Given this list of marker genes GSTA4, BGN, CDC25B, SPTAN1, GSTO1, CDKN1B, WNT5A, IL6ST, BRCA1, DAPK1, TIMP1, UMPS, TANK, ERBB2, PDGFRB, CASP1, GTF2H5, EGR3, IGFBP6, BHMT, SMAD1, IDI1, ABL1, MAP3K1, SMAD4, ERCC1, RHOB, IFNG, CCNE1, BAX, CAV1, HMGCR, BID, DVL3, PLAT (NCBI Gene Id 5327), FGF11 (fibroblast growth factor 11), FGF2, IGFBP7, TLR3, TP53, TNFRSF10A, IL1R1, BTG3, GJA1, IL6, APAF1, FGFR1, DPYD, POLG, IGF2R, SHC1, MYD88, CXCL8, IGFBP3, SMAD7, MGMT, TIMP2, CFLAR, IFNA10, TIMP3, IFNGR1, MARS1, PRKCA, IGFBP4, CDKN1A, FGF7, FANCG, GPX3, SMAD5, TYMS, IGFBP5, PDGFRA, GSTM5, DUT, IRF6, PRKACB, SHC3, GADD45A, GSTM1, MMP2, SKIL, IL1A, MAT2B, CASP6, DCTD, POLR2E, PLAUR, TNFRSF10B, DCN, IGFBP2 (NCBI Gene Id 3485), RAD23B, PTEN, PDGFD, GTF2H4, SC5D, HGF, GSTP1, EREG, BMP2, BTG2, BORCS8, JUN, FZD1, LUM, CASP7, PERP (p53 apoptosis effector related to PMP22), HSPB1, CREBBP, RNASEL, CASP3 (NCBI Gene Id 836), LITAF, FAS, FDFT1, TGFB2, YWHAQ, POLB, WEE1, MTR, here is a description of the gene set: studied in species Homo sapiens Human Gene Set: KOKKINAKIS_METHIONINE_DEPRIVATION_96HR_UP from publication Kokkinakis DM, Brickner AG, Kirkwood JM, Liu X, Goldwasser JE, Kastrama A, Sander C, Bocangel D, Chada S (PMID 16908595) Genes up-regulated in MEWO cells (melanoma) after 96 h of methionine deprivation. Methionine deprivation stress (MDS) eliminates mitotic activity in melanoma cells regardless of stage, grade, or TP53 status, whereas it has a negligible effect on normal skin fibroblasts. In most cases, apoptosis accounts for the elimination of up to 90% of tumor cells from the culture within 72 hours after MDS, leaving a scattered population of multinucleated resistant cells. Loss of mitosis in tumor cells is associated with marked reduction of cyclin-dependent kinase (CDK) 1 transcription and/or loss of its active form (CDK1-P-Thr(161)), which is coincident with up-regulation of CDKN1A, CDKN1B, and CDKN1C (p21, p27, and p57). Expression of the proapoptotic LITAF, IFNGR, EREG, TNFSF/TNFRSF10 and TNFRSF12, FAS, and RNASEL is primarily up-regulated/induced in cells destined to undergo apoptosis. Loss of Aurora kinase B and BIRC5, which are required for histone H3 phosphorylation, is associated with the accumulation of surviving multinucleated cells. Nevertheless, noncycling survivors of MDS are sensitized to temozolomide, carmustin, and cisplatin to a much greater extent than normal skin fibroblasts possibly because of the suppression of MGMT/TOP1/POLB, MGMT/RAD52/RAD54, and cMET/RADD52, respectively. Sensitivity to these and additional genotoxic agents and radiation may also be acquired due to loss of cMET/OGG1, reduced glutathione reductase levels, and a G(2)-phase block that is a crucial step in the damage response associated with enhancement of drug toxicity. Although the genes controlling mitotic arrest and/or apoptosis in response to low extracellular methionine levels are unknown, it is likely that such control is exerted via the induction/up-regulation of tumor suppressors/growth inhibitor genes, such as TGFB, PTEN, GAS1, EGR3, BTG3, MDA7, and the proteoglycans (LUM, BGN, and DCN), as well as the down-regulation/loss of function of prosurvival genes, such as NFkappaB, MYC, and ERBB2. Although MDS targets several common genes in tumors, mutational variability among melanomas may decide which metabolic and signal transduction pathways will be activated or shutdown.